Given this list of marker genes CAV3 (NCBI Gene Id 859), ANKRD23, EDN1, MIR1-1, AKAP13, MYLK3, PROX1, BMP10, PRKD1, here is a description of the gene set: studied in species Homo sapiens Any process that modulates the rate, frequency or extent of myofibril assembly by organization of muscle actomyosin into sarcomeres. The sarcomere is the repeating unit of a myofibril in a muscle cell, composed of an array of overlapping thick and thin filaments between two adjacent Z discs. Human Gene Set: GOBP_REGULATION_OF_SARCOMERE_ORGANIZATION